The following is a description of a gene set: An inflammatory response to an antigenic stimulus, which can be include any number of T cell or B cell epitopes. Mouse Gene Set: GOBP_INFLAMMATORY_RESPONSE_TO_ANTIGENIC_STIMULUS species: Mus musculus, and this is the list of marker genes: Fut7, Il10 (NCBI Gene Id 16153), Adcyap1, Npy5r, Mir155, Cxcr2, Fcer1g, H2-T23, Pnma1, Ak7, Zp3, Selenos, Rasgrp1, Ahcy (NCBI Gene Id 98842), Zfp35, Serpinb9, Park7, Cd6, Psma1, Il25, Ephb6, Ighg2b, Hmgb2, Cysltr1, Gpx1, Lta, Mkrn2, Il5ra, Npy, Kars1, Gpr17, Pla2g2d, Mir301, Fcgr3, Trav7-2, Psmb4, Notch1, Il2ra, Ext1, Btk, Cnr1, Il20rb, Ighe, A2m, C3, Il12b, Rbpj, Fcgr1, Abcc1, Nlrp6, Icam1, Kdm6b, Cd68, Nod2, Gpx2, Trem2, Ahcyl, Lilrb4a, Spn, Cd81, Rab44, Ighg1, Ccr7, Il31ra, Gata3 (GATA binding protein 3), Trex1, Ccr2, Fosl2, Fcer1a, Elane, Fcgr4, Cd28, Notch2, Cd24a, Tnf, Bdkrb2, Fcgr2b, Enpp1, Mir21a